The following is a description of a gene set: species: Homo sapiens Any process that modulates the frequency, rate or extent of endothelial cell chemotaxis. Human Gene Set: GOBP_REGULATION_OF_ENDOTHELIAL_CELL_CHEMOTAXIS, and this is the list of marker genes: FGFR1, FGF1, FGF16, TMSB4X, P2RX4, CXCL13, HRG, NOTCH1, PRKD1, LGMN, KDR, MIR424, VEGFA, PRKD2, FGF2 (fibroblast growth factor 2), MIR16-1, SMOC2, SEMA5A, FGF18, THBS1, MET, HSPB1, FGF4, MIR149